Given this list of marker genes VANGL2, PLXNC1, ITGB1, CX3CL1, CX3CR1, TREM2, TGFB3 (NCBI Gene Id 7043), DKK1, NGEF, TGFBR1, SNAI2, C1QB, DUSP3, ABCC8, PRICKLE1, C3, SARM1, FER, PIK3R1, MYLK3, IL1B, IQSEC1, MAPRE2, C1QA, EPHA4, C1QL1, ARF6, STON1, MAP4K4, KCNK13, C1QC, ADGRB3, ITGAM, here is a description of the gene set: The disaggregation of a cell junction into its constituent components. studied in species Homo sapiens Human Gene Set: GOBP_CELL_JUNCTION_DISASSEMBLY